The following is a description of a gene set: Mouse Gene Set: GOBP_MONONUCLEAR_CELL_DIFFERENTIATION species: Mus musculus The process in which a relatively unspecialized cell acquires the specialized features of a mononuclear cell., and this is the list of marker genes: Ptger4, Plcg2, Mmp14, Shb, Crtam, Ifi207, Rasgrp1 (NCBI Gene Id 19419), Tnfsf9, Gps2, Ighm, Pglyrp3 (peptidoglycan recognition protein 3), Cd46, Clec4e, Cflar, Kmt2a, Batf3, Mir873a, Zc3h8, Hdac7, Atm, Bcl3, Adgrg3, Eomes, Slamf6, Irf1, Ihh, Ccdc39, Tmem176a, Itpripl1, Wwp1, Armc5, Lilrb4b, Ighe, Abl1, Gimap5, Men1, Cd79b, Mir20a, Sirt1, Hspb1, Med1, Tlr9, Il33, Zfp36l1, Zfp35, Opa1, Kcnk18, Batf2, Casp8, Tsc1, Vav1, Xrcc6, Cd74, Tnfsf4, Stat6, Myb (NCBI Gene Id 97674), Flt3l, Ptprj, Smarcd2, Foxp1, Bak1, Hsp90aa1, Dll4, Il18r1, Cebpg, Phf14, Wnt10b, Prr7, Epsti1, Runx1, Lyl1, Ppp3cb, L3mbtl3, Slamf1 (signaling lymphocytic activation molecule family member 1), H2-Aa, Pik3r1, Il15ra, Lgals1, Arid3c, Nckap1l, Muc19, Il6ra, Pou1f1 (POU domain, class 1, transcription factor 1, NCBI Gene Id 18737), Lck, Dock11, Ifng, Cd19, Smarcc1, Mir301, Tmem98, Lfng, Dcaf1, Il18, Sema4a, Tusc2, Bcl6, Smad7, Smarcc2, Anxa1, Gm11690, Socs1, Itgb6, Fancd2, Rag2, Spi1, Kctd9, Fzd9, Nlrp3, Aire, Spn, Plcl2, Igkj5, Hdac5, Ccl19, Wnt1, Hectd1, Tcf7, Ahr, Actb, Egr3, Ezh2, Il4ra, Il3, Prdx2, Gab3, Foxp3, Yy1, Ripk1, Prkcz, Psen1, Qki, Nrarp (NCBI Gene Id 67122), Brd4 (bromodomain containing 4), Stk11, Bcl2, Socs5, Wnt4, Igtp, Cdh17, Dock10, Mertk, Irf8, Slamf8 (NCBI Gene Id 74748), Gpr183, Ptpn22, Il2ra, Btk, Gata3 (GATA binding protein 3), Top2b, Il34, Myh9, Trem2, Traf3ip2, Ror2, Mr1, Blm, Lipa (NCBI Gene Id 16889), Pla2g2d, Irf2bp2, Smarce1, Egr1, Ctsl, Laptm5, Slc25a5, Cd3d, Nkx2-3, Zbtb46, Gadd45g, Il12b, Gpr18, Fzd8, Cd3g (CD3 antigen, gamma polypeptide), Ifnb1, Vsir, Dusp10, Mink1, Prkca, Large1, Itpkb, Srf, Hlx, Hoxa7, Duxbl1, Fas, Dcstamp, Ripk3, Pou2f2, Jmjd6, Rhoa, Il9, Ada, Dicer1, Il2, Btnl1 (butyrophilin-like 1), Slc46a2, Pbx1, Itm2a, Xrcc4, H2-DMa, Myd88, Gmpr2, Tgfb1, Gimap3, Tpd52, Txk, Klhl25, Runx3, Fzd7, Fadd, Dnaja3, Ccr7, Bmyc (NCBI Gene Id 99306), Rabl3, Mndal, Il9r, Mafb, Ly9, Chd7, Scart2, Fosl2, Cdkn2a, Sh3rf1, Tlr2, Tnfaip3, C1qc, Zap70, Jag2 (jagged 2), Ubd, Rc3h1, Smarcd3, Pparg, Ager, Ctnnbip1, Rnf41, Batf, Pik3r6, Itgb8, Nfatc3, Hmga1, Ms4a1, Lep, Azi2, Psap, Il4i1, Foxo3, Ifi209, Bad, Cd44, Adipoq, Nfkbiz, Zeb1, Nr3c1, Tyro3, Bax, Ifi203, Sp3, Lyn, Ccr6, Tnfsf13b, Ccr2, Rps6, Cyp26b1, Hs1bp3, Hmgb1, Cd79a, Foxj1 (forkhead box J1), Ccl20, H2-Oa, Ppp2r3c, Tespa1, Braf, Nfil3, Axl, Fbxo7, Prex1, Nfatc1, Enpp1, Smarcb1, Fes, Cracr2a, Trpm2, Tnfrsf9, Fzd5, Bmp4, Adrm1, Hmgb3, Cyld, Adam17, Stat3, Syvn1, Themis, Ly6d, Mir150, H2-M3, Abl2 (NCBI Gene Id 98214), Pknox1, Btn2a2, Rpl22, Ptcra, Gm36723, Lef1, Spib, Kdelr1, Rorc, Stat5a, Runx2, Vegfa, Sart1, Ifnar2, Nfkbid, Sash3, Ltbr, Ap3d1, Il21, Acin1, Skint1, Slamf9, Lif (leukemia inhibitory factor), Entpd7, Lepr, Il11ra1, Il12a, Atp11c, Il15, Rbpj, Atf2, Smarcd1, Nfix, Kat7, Ep300, Jak3, Ctsk, Ifi214, Gba1, Card11, Clec4g, Cd83, Mfng, Prtn3, Mir19a, Rara, Zfp36l2, Otud5, Fanca, Mtor, Cmtm7, Dnajb9, Traj18, Vps13a, Ifi208, Il1rl2, Ncor1, Zfp683, Tmem131l, Cbfb, Csf1, Fnip1, Ddrgk1, Cd8a, Jun, Nhej1, Dock2, Tnfsf18, Fcer1g, Naglu, Vps54, B2m, Stat5b, Hells, Xbp1, Eif2ak1, Il1b, Csf2, Carmil2, Gpr89, Tgfbr2, Diaph3 (diaphanous related formin 3), Irf4, Ctla4, Lmbr1l, Sh2b3, Lgals8, Il7r, Clptm1, Actl6a, Apcs, Ndp, Foxn1, Atp7a, Clcf1, Pglyrp4, Clec4d, App, Pde1b, Hsf1, Dtx1, Notch2, Il36b, Gas6, Ripk2, Brd7, Cd27, Polm, Zbtb7b, Smarca2, Mir92-1, Plcb1, Zbtb7a, Ifi203-ps, Vnn1, Tmem176b, Pirb, Gimap1, Fasn, Ifi206, Cd28, Gata2, Gon4l, Cd4, Lrrc8a, Cd1d1, H2-Ea, Pir, Sox13, Apc, Prkdc, Kat2a, Fgl2, Nfam1, Mfsd8, Atg5, Tbx21, Tbk1, Hdac9, Arid1a, Stat4, Thoc5, Ptpn6, Zc3h12a, Dclre1c (NCBI Gene Id 319261), Mir326, Asxl2, 6030468B19Rik, Pglyrp1, Slc39a7, Slc4a2, Actl6b, Ucp2, Lag3, Drosha, Ighg1, Bcl2a1d, Pnp, Il10, Rsad2, Ap3b1, Pglyrp2, Arid2, Syk, St3gal1, Ambra1, Ctnnb1, Hotairm1, Itk, Loxl3, Usp44, Inpp5d, Ptprc, Aqp8, Mir17, Igkc, Ifnz, Il7, Trp53, Sos1, Ankle1, Pax1, Clec12a, Il1rl1, Pou2af1, Traf6, Bcl11b (B cell leukemia/lymphoma 11B), Mettl3, Kat5 (NCBI Gene Id 81601), Gpr68, Sfrp1 (secreted frizzled-related protein 1), Prelid1, Ctla2a, Gli3, Tcirg1, Zfp608, Il2rg, Tcf3, Pf4, Itfg2, Malt1, Flt3, Cd3e, Pbrm1, Prdm1, Lilrb4a, Zmiz1, Mpzl2, Psmb11, Sos2, Rc3h2, Patz1 (POZ (BTB) and AT hook containing zinc finger 1), Dll1, Ptpn2, Gata1, Trib1, Ifi213, Id2 (inhibitor of DNA binding 2), Relb, Tnfsf8, Cebpa, Smarca4, Mdk, Zfp609, Rb1, Msh2, F2rl1, Nkap, Ndfip1, Il6, Rora, Itgam, Sox4, Tshr, Cd24a, Tspan2, Ntrk1, Ncaph2, Zbtb1, Shh, Fut7, Mir18, Nrros (NCBI Gene Id 224109), Satb1, Ccr9, Cr2, Lig4, Il23a, Il31ra (interleukin 31 receptor A), Brd2, Pcid2, Cacnb4, Tox, Btnl6, Ascl2, Hcls1, Cebpb, Lgals9, Ptk2b, Pck1, Cebpe, Rag1, Kit, Cd40lg (NCBI Gene Id 21947), Hhex, Mef2c, Ikzf3, Adam8, Sox12, Myc, Phf10, Csf1r, Ikzf1, Cd69, Onecut1, Mir19b-1, Camk4, Rhoh, Cdk6, Erbb2, Fos, Bmi1, Il4, Il27, Il1a, Dpp4, Tlr4, Bcl11a